Given this list of marker genes ARHGAP1, FAM83B, TXNL1, TNFAIP1, DEPDC1B, VANGL1 (VANGL planar cell polarity protein 1), UBXN11, LRRC1, RBMX, BLTP3B, FRS3, KIDINS220, DST, CKAP4, KTN1, FRS2 (fibroblast growth factor receptor substrate 2), FNBP1, DSG1, ANKRD26, RND2, CAV1, PTPN13, TFRC, DLG5, PRAG1, PLXND1, WDR6, SCRIB, KCTD13, ALDH3A2, MUC13, NUDC, EPHA2, NISCH, PIK3R2, ARHGAP5, VANGL2, LEMD3, PIK3R1, GOLGA3, ARHGAP35 (Rho GTPase activating protein 35), KIF14, PKP4, here is a description of the gene set: studied in species Homo sapiens RND2 (RHON) is an atypical RHO GTPase and the least studied member of the RND subfamily. RND2 is constitutively bound to GTP and lacks GTPase activity. No guanine nucleotide exchange factors (GEFs), GTPase activator proteins (GAPs) or guanine nucleotide dissociation inhibitors (GDIs) act on RND2. RND2 is predominantly expressed in brain, testis and liver. RND2 regulates neurite outgrowth and branching and migration of newborn neurons within the embryonic cerebral cortex. Reactome Pathway: RND2 GTPase cycle part of: RHO GTPase cycle